Given this list of marker genes MAP2K7, MAP2K1, NLRP1, TNF, VCAM1, ANTXR2, IL1B, MAPK3, MAPK1, PGR, MAP2K3, DEFA1, IL18 (NCBI Gene Id 3606), ANTXR1, MAP2K4, CASP1, MAP2K2, MAP2K6, here is a description of the gene set: species: Homo sapiens Cellular roles of Anthrax toxin from publication Schaefer CF, Anthony K, Krupa S, Buchoff J, Day M, Hannay T, Buetow KH (PMID 18832364) Human Gene Set: PID_ANTHRAX_PATHWAY